Given this list of marker genes MSMO1, TOX4, MGAT3, IFT122, CASP8, STAT1, CPLANE1, ETNK1, CD8B, DNAJA4, VIRMA, STXBP3, KISS1R, CUL2, RASGEF1B, TRIM14, AKT3, SYNJ1, TMEM225, ADAMTSL3, ACYP2, HDAC1, TENT4A, NVL, ELFN1, LAMP2, TMED5, SETDB2, CERS6, SPAG5, CISH (NCBI Gene Id 29917), SLFN13, KRCC1, ISL2, ARMCX2, WDR38, HSD17B7, FGL2, IGSF10, PRDM1, EDNRB, AREG, IK, CCND2, EHD2, ACOD1, IFT22, MARCKSL1, TRIR, RAB5IF, GLIPR1, STAT6, MAX, CACNB2, MTHFS, C11orf52, FZD5, ACCSL, UBA3, TP53BP2, GTF3C6, CIT, AHCYL2, POU6F1, IFITM3, SDC3, RAB18, SLC26A3, ST6GALNAC5, LCP1, LLGL1, AMN, ATF3, EAF2, FBXO46, JAK2, HAT1, CUTC (cutC copper transporter), CCL20, RBMX, CPD, BRME1, FAAH, STRIP2, POSTN, MTMR14, TNF, USB1, CYP51A1, HRCT1, FLNB, CD200R1, ZC2HC1A, MVP, TRAF2, WARS1, TAPBP, LINC01160, BAZ1A, MECP2, SOX6, PML, MAB21L3, CSRP1, LYST, TMEM140, EVI2A, RFTN1, SUZ12, TMOD3, TLR3, PNPLA1, PRRG4 (proline rich and Gla domain 4), IRF2, INTS8, CYB5B, TASL, ACOT9, HCK (NCBI Gene Id 3055), TRIM56, VWA5A, TREML4, INPP5B, ABCB1, CD86, EPN3, EEF1AKMT2 (EEF1A lysine methyltransferase 2), SIPA1L1, MYCBP2, VPS54, YBX2, HTT, TAF12, PAPPA2, SLC2A6, NPNT, MSRB3, CD200R1L, CDK6, CSF1, PSME2, EVI2B (NCBI Gene Id 2124), PDZD8, SRSF5, PPFIBP1, VRK2, ZNF213 (NCBI Gene Id 9233), CPNE2, RPS6KL1, OGDH, UTS2R, CCNYL1, AXL, USP40, TBC1D1, HSDL2, SAP30, ATP6V0A1, MTOR, IL4I1, CD38, CLTC, PSME1, RBM11, MAT2A, SPRED1 (NCBI Gene Id 161742), EPCIP, TGFB3, SETD3, TTC21B, ANGPT1, MACC1, OPTN, BCL2A1, POR, ICAM1, PGGT1B, MBD5 (methyl-CpG binding domain protein 5), MRPL39, ARL14, OAS1, AGFG1, SLC39A12, NAB1, MAPKAPK2, ARID2, SSBP1, TREML1, ZCCHC24, PKP4, TMEM223, MPI, TUBGCP4, KIAA1958, HNRNPH2, TTC9B, NABP1, ARL6IP1, CCL5, here is a description of the gene set: Human Gene Set: GSE46606_IRF4HIGH_VS_IRF4MID_CD40L_IL2_IL5_DAY3_STIMULATED_BCELL_DN from publication Ochiai K, Maienschein-Cline M, Simonetti G, Chen J, Rosenthal R, Brink R, Chong AS, Klein U, Dinner AR, Singh H, Sciammas R (PMID 23684984) studied in species Homo sapiens Temporal analysis of B cell activation in vitro using CD40L and IL-2/4/5 cytokines in wild type Irf4+/+ B cells or in mutant Irf4-/- B cells harboring a tet-inducible allele of Irf4. IRF4 expression was restored, or not, in the Irf4-/- background by culturing in the presence of low or high concentrations of doxycycline. The results provide insight in the role of IRF4 expression levels in coordinating different programs of B cell differentiation. Genes down-regulated in CD40L and IL-2 IL-4 IL-5 stimulated at day 3 B cell IRF4high versus CD40L and IL-2 IL-4 IL-5 stimulated at day 3 B cell IRF4intermediate.